The following is a description of a gene set: studied in species Homo sapiens Human Gene Set: GSE18281_MEDULLARY_THYMOCYTE_VS_WHOLE_MEDULLA_THYMUS_UP Interaction of hematopoietic progenitors with the thymic stromal microenvironment induces them to proliferate, adopt the T cell fate, and asymmetrically diverge into multiple T lineages. Progenitors at various developmental stages are stratified among different regions of the thymus, implying that the corresponding microenvironments differ from one another, and provide unique sets of signals to progenitors migrating between them. The nature of these differences remains undefined. Here we use novel physical and computational approaches to characterize these stromal subregions, distinguishing gene expression in microdissected tissues from that of their lymphoid constituents. Using this approach, we comprehensively map gene expression in functionally distinct stromal microenvironments, and identify clusters of genes that define each region. Quite unexpectedly, we find that the central cortex lacks distinctive features of its own, and instead appears to function by sequestering unique microenvironments found at the cortical extremities, and modulating the relative proximity of progenitors moving between them. from publication Griffith AV, Fallahi M, Nakase H, Gosink M, Young B, Petrie HT (PMID 20064453) Genes up-regulated in medullary thymocytes versus thymus whole medulla., and this is the list of marker genes: ASL, DGUOK, CSNK1D, PYCARD, SLC26A11, WDR72, PIGK, CCKBR, MAP2K2, SCOC-AS1, EPRS1, MFHAS1, JUNB, SLC35B3, EYA4, PAXIP1 (NCBI Gene Id 22976), HISLA, IL5RA, SSU72, PI15, ST3GAL1 (ST3 beta-galactoside alpha-2,3-sialyltransferase 1), FKBP1A, DENND11, CXCL1, DHX30, JADE1, CEACAM1, ZBTB10, NR4A2, RHOF, SERPINI1, MRPL52, PRSS54, DPPA2, PRC1, PAQR7, AVPR1B, PBXIP1, IL18R1, PLG, SPSB2, NAA10, SLC22A25, KLHL30-AS1, C17orf99, FBXL7, LAIR1, SKA3, SMG9, ASH1L, TRAF3IP3, IRAK2, ARHGAP9, IFT80, SFXN1, TAOK1, PTTG3P, NUDT1, SDR39U1, CENPK, LAGE3 (L antigen family member 3), MICAL2, DSG3, CXCL2, TBCD, MBP, NFATC1, TEX10, SH3PXD2A-AS1, MMP9, PLIN5, TIAM1, LPCAT2, ZSCAN18, POGLUT1, SORT1, CYP2R1, ENTR1, ARRDC2, GPX4, ALOX5AP, LMO2, LINC01565, PLXDC2, LTB, BTC, STX7 (NCBI Gene Id 8417), NCR2, ST6GALNAC2, AKAP9, C14orf28, ARHGEF6, MYH10, FAU, TNFRSF1B (NCBI Gene Id 7133), NQO2, PIH1D1, CNPY3, ARFGAP1, MAGED1, HEMK1, RPL31, ENHO, SCAND2P, FEZ1, FAR2P2, ZBTB25, MAN2B2, OR7C1, KRT35, CELF3, PLEKHJ1, UBTD1, PAGR1, DNAJB6, LINC00926, RPTOR, TAF3, MYCBP, KLHDC8A, DDB2, MZT2B, DUS1L, ACP6, ATP5MC1, PDE4A (NCBI Gene Id 5141), INTS8, CD79B, TRAPPC12, FBXO42, EMB, ZNF641, STK11, ENG, CLN3, AGPAT2, ERCC6L2-AS1, FBXO25, R3HCC1, ZYG11A, VWA5A, HERC2, NEFH, AP1G1, ZNF862, GNG11, H1-3, TXN2, FBP1, BRD9, RPL15, TRPT1, ERMARD, RDH8, RAB7B, FBH1, RAPGEF1, GALR2, IL3RA, G0S2, RPS6KA1, BSCL2, PRDX6, MAMDC2, NMT2, DEF6, CCDC28A, ETFB, IL10RA, RAB3D, ZNF628, BTK, ASF1B, UTS2B, IFNAR2, ZNF768, CHST2, FXYD2, ACTMAP, JAML, HLX, ENKUR, GGA1, TLN1, KIAA1586, ZNF674-AS1, WEE1, PKD1P1, CLCN5, CHN2, H2AX (NCBI Gene Id 3014), MEN1, RELB, SURF1, HGS